The following is a description of a gene set: During cellular differentiation and development, it is recognized that many complex molecular mechanisms as well as precise patterns of differentially expressed genes occur in directing precursor cells toward a given lineage. Using microarray-based technology, we examined gene expression across the course of 3T3-L1 adipocyte differentiation. Total cellular RNA was isolated at times 0, 2, 8, 16, 24, 48, and 96 h following treatment with either standard hormonal inducers of differentiation; insulin, dexamethasone, isobutylmethylxanthine (IDX), or IDX plus trichostatin A (TsA), a histone deacetylase inhibitor and potent adipogenic inhibitor. cRNA was synthesized from cellular RNA and hybridized to high density Affymetrix MG_U74Av2 microarray gene chips containing 12,488 cDNA/Expressed Sequence Tags (ESTs) probe sets. From the IDX-only treated cells, all probe sets that were either unchanged or differentially expressed less than 2-fold throughout differentiation with respect to time 0 preadipocytes were excluded from further analyses. This selection resulted in a net of 1686 transcripts, 859 were increased in expression, and 827 were decreased in expression at least 2-fold across differentiation. To focus in on genes that were more specific to differentiation, the same analysis was performed on IDX plus TsA-treated non-differentiating cells and all probe sets from the IDX-only group that exhibited similar expression profiles in the non-differentiating TsA-treated group were excluded leaving a total of 1016 transcripts that were regulated only under differentiating conditions. Six hundred and thirty-six of these transcripts were elevated at least 2-fold and 380 exhibited a decrease in expression relative to time 0 preadipocytes. This group of genes was further analyzed using hierarchical clustering and self-organizing maps and resulted in the identification of numerous genes not previously known to be regulated during adipocyte differentiation. Many of these genes may well represent novel adipogenic mediators and markers of adipogenesis. species: Mus musculus Strongly up-regulated at 8 h during differentiation of 3T3-L1 cells (fibroblast) into adipocytes. Human Gene Set: BURTON_ADIPOGENESIS_2 from publication Burton GR, Nagarajan R, Peterson CA, McGehee RE Jr (PMID 15033539), and this is the list of marker genes: SAR1B, IVNS1ABP, PER2, GJA1 (gap junction protein alpha 1), ST3GAL1 (NCBI Gene Id 6482), NSUN2, SLC6A6, PRDX6, SAMHD1, HSPD1, PTGES, FST, MAP3K6, RAMP3, HMGA2, GRWD1, VDR, TLE1, GSTO1, SRR, SPHK1, TLL1, AVPI1, HSPH1, SFPQ, CLIC4, XDH, MCL1, RBM14, FTSJ3 (NCBI Gene Id 54803), TUBB3, TGFBR3, CAD, FOSL1 (NCBI Gene Id 8061), SERP1, PRR5, COL4A1, SDC1, SPSB1, LIMK1, PGD, SRXN1, NF2, KRT13, FKBP5 (FKBP prolyl isomerase 5), PRKCE, GNPTAB, RHOU (NCBI Gene Id 58480), ANK3, LXN, UGDH (UDP-glucose 6-dehydrogenase), RASA3, CCND3, NOP56, SNAI1, ITGA5, SIDT2, SASH1, KCNN4, SRM, TPM4, PA2G4, TEAD4, MKNK2, RHOJ, BCAT1, SLC7A6, IL1R1, TIMP1, IL1RL1, HSF1